The following is a description of a gene set: Binding to a member of the tumor necrosis factor receptor superfamily. species: Mus musculus Mouse Gene Set: GOMF_TUMOR_NECROSIS_FACTOR_RECEPTOR_SUPERFAMILY_BINDING, and this is the list of marker genes: Tnfsf14, Bex3, Tradd, Fasl, Bdnf, Tnfsf10, Nsmaf, Casp8, Tnfsf8, Traf4, Dab2ip, Fem1b, Tnfsf9, Babam2, Fadd, Tnfsf12, Nol3, Ltb, Tnfsf15, Tnfsf13, Traf1, Tnfsf18, Tnfsf4, Adam8, Tmbim1, Edaradd, Casp3, Traf6, Traf3, Traf5, Ntf3, Ngf, Tnfsf13b, Cd70, Nucb2, Tnfsf11, Prdm4, Eda, Erap1, Ntf5, Stat1, Tnf, Traf2, Lta, Cd40lg, Siva1, Trim37, Cflar, Ripk1